Given this list of marker genes BMP1, AIFM1, PHEX, TP53, KIAA0586, RB1, EZH2, TRIP11, TRPV4, CHEK2, RASA1 (NCBI Gene Id 5921), CSPP1, PAM16, SRP54, CFAP410, COL10A1, COL11A2, COL2A1, COMP, DNAJC21, GNPNAT1, FGFR3, SBDS, UFSP2, SETBP1, here is a description of the gene set: Human Gene Set: HP_ABNORMAL_LOWER_LIMB_METAPHYSIS_MORPHOLOGY Abnormal lower-limb metaphysis morphology studied in species Homo sapiens